Given this list of marker genes Pla2g10, Il22, Pycard, Cuedc2, Il22ra1, Adcy7, Ezh2, Abcd1, Apod, Prkca (protein kinase C, alpha), Pdcd4, Spink7, Hmox1, Lilrb4b, Ppara, Extl3, Chrna7, Lilrb4a, Jak2, Appl2, Trem2, Reg3g, Mefv, Ephb2, Chid1, Nlrc3, Abcd2, Macir, Sirpa, Stat3, Zc3h12a, F2, Il1r2, here is a description of the gene set: Mouse Gene Set: GOBP_NEGATIVE_REGULATION_OF_CYTOKINE_PRODUCTION_INVOLVED_IN_INFLAMMATORY_RESPONSE studied in species Mus musculus Any process that stops, prevents or reduces the frequency, rate or extent of cytokine production involved in inflammatory response.